Given this list of marker genes SLC35B1 (NCBI Gene Id 10237), SLC35B4, SLC35C1, SLC35A3, SLC35D2, TMEM241, SLC35C2, SLC35D1, SLC35A2, SLC35A1, SLC35A4, SLC35A5, SLC35D3, here is a description of the gene set: Human Gene Set: GOBP_NUCLEOTIDE_SUGAR_TRANSMEMBRANE_TRANSPORT The directed movement of nucleotide-sugars into, out of or within a cell, or between cells, by means of some agent such as a transporter or pore. Nucleotide-sugars are any nucleotide in which the distal phosphoric residue of a nucleoside 5'-diphosphate is in glycosidic linkage with a monosaccharide or monosaccharide derivative. species: Homo sapiens